The following is a description of a gene set: from publication Xie X, Lu J, Kulbokas EJ, Golub TR, Mootha V, Lindblad-Toh K, Lander ES, Kellis M (PMID 15735639) studied in species Homo sapiens Comprehensive identification of all functional elements encoded in the human genome is a fundamental need in biomedical research. Here, we present a comparative analysis of the human, mouse, rat and dog genomes to create a systematic catalogue of common regulatory motifs in promoters and 3' untranslated regions (3' UTRs). The promoter analysis yields 174 candidate motifs, including most previously known transcription-factor binding sites and 105 new motifs. The 3'-UTR analysis yields 106 motifs likely to be involved in post-transcriptional regulation. Nearly one-half are associated with microRNAs (miRNAs), leading to the discovery of many new miRNA genes and their likely target genes. Our results suggest that previous estimates of the number of human miRNA genes were low, and that miRNAs regulate at least 20% of human genes. The overall results provide a systematic view of gene regulation in the human, which will be refined as additional mammalian genomes become available. Human Gene Set: TGCCAAR_NF1_Q6 Genes having at least one occurrence of the highly conserved motif M47 TGCCAAR in the regions spanning 4 kb centered on their transcription starting sites. This matches the NF1 transcription factor binding site V$NF1_Q6 (v7.4 TRANSFAC)., and this is the list of marker genes: PSMC5, SIK1, THRSP, SUPT3H, ABRA (NCBI Gene Id 137735), STIM1 (stromal interaction molecule 1), GHR, ID3, VAMP2, MIR600HG, MORF4, APTX, C1QTNF3, CIMIP6, SLCO1C1, TGM4, CALM1, CRX, TSSK6, PRDM13, ACVR1, CACNA1D, AMOTL1, SCOC, SNX10, PNRC2, WBP1L, FAM120C, IRS1 (insulin receptor substrate 1), KRT8P41, LRRFIP2, RRBP1, SPRY4, COL4A3 (NCBI Gene Id 200750), FOXN3, LRRK1, AGER, GPR183 (G protein-coupled receptor 183), RBMS2, ENPP2, ARRB2, UBXN1, IRAG1, PLEKHA6, CMYA5, TSPAN6, MESP1, DTNB, MIR22HG, SKAP1, OR11L1, SUPT16H, MAP3K20, GJB6, ARMC8, DMD, HIRA, CIPC, ADRB2, NECTIN1, ANP32A, IL16, AKAP4, HS3ST4, MSS51, FBLIM1, EHF, LARP4, PAFAH2, CYRIA, ESRRG, EDN1, KLHL32, TNPO3 (transportin 3), B3GAT3, SAMD12, FAM53B, ZNF821, LMO3, COLEC12, FAM110D, SOAT1, DDX17, CAVIN2, SLC26A7, MDGA2 (NCBI Gene Id 161357), SLC26A9, SLC38A4, SMTNL2, GPLD1, CLC, MAP3K15, OR52J3, UGT1A1, SERPINB5, NCALD, ACO1, RINT1, ACTG2, CRK, LINC03040, JDP2, PDRG1, PDE1A, APOC4, GABRA6, MECOM, RBFOX1, G3BP2, LINC00472, FLRT3, HOXA10 (NCBI Gene Id 3206), CDC42EP3, CALM3, PCBP4, CPXM2, DNAJB4, NCAM1, PMP2, SYT4, CCDC116, RAB5C, EMILIN1, CSRNP1, PDHA1, RARA, NAP1L3, YBX1, ERBB2, ARHGEF6, AGPAT1, UBE2H, ROR1 (receptor tyrosine kinase like orphan receptor 1), KRT17, CALM2, NFIA, POSTN, PRKAG1, SLC5A3, RNF213, GSX1, CHMP2B, UGGT1, NOX3, OPHN1 (oligophrenin 1), CLIC5, RAB27A (RAB27A, member RAS oncogene family), TMEM109, SSTR3, NR2F1, RAPGEF4, PI16, CRTC2, PPARG, RBM14, MAP1A, IFNK, SYNCRIP, PAPLN, ZDHHC1, LINC00314, ZIC2, GCNT2, IKZF2, PRPF39, NPHP4, SCAF11, RALY, NFATC2, TLCD3B, VWA1, NTRK3, MTCH2, ZNF711, SDCCAG8, MEF2A, AHSG, DNAL4, ELF4, SFRP2, ITIH2, ESR1, XDH, IRX5, GNAO1, ATP6V1E2, PEX5L, ISG15, FOXA2, KLF7, COL4A4, FAM91A1, IVNS1ABP, CCL3, HPSE2, CAMKMT, FMNL1, NDUFA13, KRT83, MYH2, HLX, LGALSL, MINDY2, CFAP53, MITF, NRP2, STX18, NFIB, HGF, WDR47, WNK1 (WNK lysine deficient protein kinase 1), SP1, MYBPC1, PDZRN4, BACH2, MAP4K3, H1-0, KLF12, DHRS3, FOXP2, LYPD1, AXIN2, IL19, FTSJ3, PLXNB1, STK33, CITED2, GJA3, KCNB2, ILRUN, SKIDA1, PGAP1, KIF13A, HOXA2, EPHA3, GDF1, HMGN2, CFAP68, DCT, RLF, DUSP4, GPD1, GIP, PPP1R2B, PELP1, SPEM1, PRELP, KCNE5, SEPTIN14 (NCBI Gene Id 378074), HTR2C, PHEX, C4B, LAMB2, AGAP2, MTRFR, DLG2, SRGAP2, P2RY4, CNN1, MYL2, KCNK3, FAM107B, CLDN10, MOXD1, CBFA2T2, PBXIP1, EPHB2, PABPN1, CALCA, PRR14L, HSPB2, SPOP, ADARB2, PUM2, NEMF, EIF1AD (NCBI Gene Id 84285), LIN54, SEMA6A, TIMM8A, FMOD, LINC01931, CCN5, YBX2, MPL, GRID2 (glutamate ionotropic receptor delta type subunit 2), ARHGEF12, TAOK3, RAI14, PITX1, PPP2R5B, DCSTAMP, OGN, RRAD, HSPB3, CHAT, EIF4EBP3, CXCL17, KIT, KANSL1L, RNF139, CD55, ABCA9, PRDM8, PCDH7, TMSB10, SYNGR1, LIFR, CACNA2D3, HECTD1, CACNB2, PTK7, NAV3, GDAP1L1, PPP2R2C, ABLIM2, MYH8, ALB, ANP32D, SH3BGRL3, PTHLH, MGAT4C, PREPL, PROX1, TMEM71, HR, ETV3, ETV4, IQSEC1, BTRC, DLG3, MET, HOXD8, PROK2, DST, PIPOX, DMBT1, IDH2, CKAP4, EMCN, INHBC, CACNB3, ZEB2, NAPB, NHERF1, CERS1, GRPEL2, CUEDC1, TLX3, SOX4, ZNF267, PODN, DDO, ITGA7, BNC2, PRKAG3, ANKRD12, RNF144B, HPGD, CPNE1, LIN28A, COPG2, SLC25A35, ROBO1, QRSL1, PPP2R5E, APOA2, SUDS3, PTK2, ZMYND8, PLXNC1, TIGD4, IRX6, OLFM1, ST8SIA2, C6orf62, RIN2 (Ras and Rab interactor 2), RBSN, PHYHIPL, EIF4ENIF1, SRPX2, DCLK1, HECTD2, DLX3, RARB, TSPAN7, PLXNA2, NUDT8, TBRG1 (transforming growth factor beta regulator 1), CXCL14, IGSF1, IL2RA, TOMM22, NR3C2, CHODL, SORBS2, CDKN2C, HHIP, C4A, GPR173, SPMIP6, WDR81, PITX2, FAM124A, PRR16, STMN4, RRP15, ARL14EP, ST6GALNAC5, RAB8B, NANOS1, GDPD2, MFF, TSLP, DDIT4, ETV5, RHBDL3, BBOX1, PRR34, PATL1, RORA, MIR137HG, BPTF, HAGHL, MTAP, MFSD2A, REG3G, TMEM192, HMGA2, CHD6, PPTC7, WNT10A, AMOTL2, PPP6R3, NFIX, SAMM50, GSC, PSMA8, SOBP, CD4, HTR3B, SMOX, OPN1LW, KIF21A, SLC9A9, AAK1, CTNNA3, CHAD, IGSF22, PSMF1, ADAM12, RMND5A, TOM1L2 (NCBI Gene Id 246315), PCGF1, PRSS35, HCN1, FRMD5, SLITRK6, MYOT, FLT4, TENT5A, PER2, FZD4, CALD1, SYTL2, ESAM, RPP21, KLF1, SMARCA2, RGN, CPNE6 (NCBI Gene Id 9362), C3orf36, KY, MSTN, DCHS2, MYH3, MOAP1, CDK6, H6PD, AQP11, IGFBP6, FABP3 (fatty acid binding protein 3), ABHD5, CCN1, SYT9, BCAS4, GFAP, TCF4, PALMD, AGR2, VEGFD, SPAG9, MED13, BRINP1, LMO4, ZNF654, MIP, MKS1, DDIT3, THAP11, DACT1, NALCN, VPS13B, CS, OSR1, C1QTNF1, TGM5, CYLD, STAT3, KLHL2, PID1, EVA1C, ARIH1, MPC2, KIF24, FAM180A, MIER3, IRS2, P2RY10, ADCYAP1 (NCBI Gene Id 116), SP6 (Sp6 transcription factor), PEX7, CYP11A1, EIF4G1, TPI1, CLCN5, C1orf122, MAB21L2, POU2F1, MAP4K5, LRRC2, MYL3, TPI1P2, TMEM126B, CPEB4, DLX1, LINC01559, NAA60, BMERB1, OSBPL7, DRC3, PAG1, PER3, KRT76, NDST2, EGR2, MAT2A, ELP5, BCL6, FEZF2, MB21D2, DUSP2, MYH4 (NCBI Gene Id 4622), MAB21L1, CYP17A1, LMNA, B3GALT2, ZNFX1, IFT43, FLRT1, LCN2, UBP1, CACNA1C, PAX2, AP1AR, WDTC1, CDH10, RETNLB, SLC6A11, MAPT, TLR8, HPN, TXLNGY, NDRG2, AQP9, RANGRF, ADD3, DSCAML1, PRKACA, RPS6KA5, LANCL1, BICD1, CDK2AP1, PAQR6, KCNT2, OMD, ASIC1, OLFML2A, SRF, C2CD6, MAGEL2, MAST4, NFYB, MARK2 (NCBI Gene Id 2011), NXF1, PIGP, ZMYM2, BCORP1, EBF2, BNC1, TRPS1, SIAH3, FAP, CTDNEP1, R3HDML, NUDT10, GPR21, ABCB6, LMOD3, ARCN1, RUNX1T1, TCAIM, LTBP2, LINC01106, PLCB1, SHOX2, UBL4A, ARL4D, FRS2, TPM3 (tropomyosin 3), ZCCHC3, STAC, CCDC78, RBP4, MEIS2, ARHGAP6, NLGN3, TIMP3 (NCBI Gene Id 7078), MCU, OTP, ESRP1, NNAT (neuronatin), LEF1, TTC39B, COLCA1, XKRX, KRT4, TGFB3, PLP1, GMPPB, RC3H2, ATP6V0C, CHMP1B (charged multivesicular body protein 1B), CNTNAP4, JADE1, WARS1 (tryptophanyl-tRNA synthetase 1), SCRT2, ERG, SLIT3, NEUROD2, MED27, RNF183, BZW2, MYH1 (myosin heavy chain 1), ATP2A3, RIT1, NEDD4, H1-10, TRIM8, MUSK, SLC15A2, PPP1R9B, KIF13B, BDNF, PHYHIP, ZIC5, TARS3, SLC35G2, FAM133A, GPR22, ZNF462, GNAT2, GAB2 (NCBI Gene Id 9846), PLPP5, VSNL1, MVP, PTPN21, PHOX2B (NCBI Gene Id 8929), ADCY1, PI15, LRRC8A, TNNI1, PLS3, VNN2, PRDM2 (NCBI Gene Id 82680), PTCH1, HOXB1, LRRN4CL, HRC, CCNY, POU4F1, HNF1A, TMEM86B (NCBI Gene Id 255043), WDPCP, FGF21, KCNQ4, SLC35B1, DGKD, SLC22A17, MYH13, CRYAB, PPM1D (NCBI Gene Id 8493), ECI1, RCOR2, FUT7, ARTN, GOT1, SIX2, EPHA5, UBE2R2, RTN4IP1, MBNL1 (muscleblind like splicing regulator 1), CD2BP2 (NCBI Gene Id 10421), ARFIP1, RANBP9, FAM13B, CBX4, SERPINB13, MRPL40, ANKFN1, NRK, CNP, HNRNPF, NUMBL, LRRTM3, SPIN1, CAMKK1, DSG1